The following is a description of a gene set: Human Gene Set: GOMF_STRUCTURAL_CONSTITUENT_OF_POSTSYNAPTIC_SPECIALIZATION The action of a molecule that contributes to the structural integrity of a postsynaptic specialization. studied in species Homo sapiens, and this is the list of marker genes: DLG1, PPFIA2, RAPSN, GIT1, SHANK1